The following is a description of a gene set: A process in which force is generated within skeletal muscle tissue, resulting in a change in muscle geometry. Force generation involves a chemo-mechanical energy conversion step that is carried out by the actin/myosin complex activity, which generates force through ATP hydrolysis. In the skeletal muscle, the muscle contraction takes advantage of an ordered sarcomeric structure and in most cases it is under voluntary control. studied in species Mus musculus Mouse Gene Set: GOBP_SKELETAL_MUSCLE_CONTRACTION, and this is the list of marker genes: Actn3, Homer1, Dmpk, Strit1, Chrnb1, Prkd1, Tnni3, Casq1, Selenon, Ccdc78, Synm, Myh3, Tnnt3, Tcap, Dmd, Cav3, Hsp90aa1, Chrng, Jsrp1, Scn4a, Kcnj2, Adrb2, Rcsd1, Tnnt1, Stac (src homology three (SH3) and cysteine rich domain), Rps6kb1, Nr4a1, Slc8a3, Tnnc2, Ddit3, Tnf, Myh8, Chrne, Myh14, Tnni2, Myh7, Atp2a1, Kbtbd13, Tnnc1, Grcc10, Mylk2, Chrna1, Tnni1, Gaa (NCBI Gene Id 319889), Stac2, Stac3, Rem1, Chrnd, Atp8a2